Given this list of marker genes PARS2, PPA2, RARS2, YARS2, CARS2, SARS2, WARS2, DARS2, NARS2, VARS2, EARS2 (glutamyl-tRNA synthetase 2, mitochondrial), AARS2, KARS1, MARS2, HARS2, FARS2, TARS2, QARS1, IARS2, LARS2, GARS1 (glycyl-tRNA synthetase 1), here is a description of the gene set: Mitochondrial tRNA aminoacylation Human Gene Set: REACTOME_MITOCHONDRIAL_TRNA_AMINOACYLATION studied in species Homo sapiens